The following is a description of a gene set: Genes down-regulated in comparison of regulatory T cell (Treg) from mice infected with S. mansoni versus T effector cells from the infected mice. from publication Layland LE, Mages J, Loddenkemper C, Hoerauf A, Wagner H, Lang R, da Costa CU (PMID 20007528) Although several markers have been associated with the characterization of regulatory T cells (Treg) and their function, no studies have investigated the dynamics of their phenotype during infection. Since the necessity of Treg to control immunopathology has been demonstrated, we used the chronic helminth infection model S. mansoni to address the impact on the Treg gene repertoire. Before gene expression profiling we first chose to study the localization and antigen-specific suppressive nature of classically defined Treg during infection. Presence of Foxp3+ cells were found especially in the periphery of granulomas and isolated CD4+CD25hiFoxp3+ Treg from infected mice blocked IFN-gamma and IL-10 cytokine secretion from infected CD4+CD25- effector T cells (Teff). Furthermore the gene expression patterns of Treg and Teff showed that in total genes were significantly regulated during chronic schistosomiasis. Upon k-means clustering we identified genes exclusively regulated in all four populations including Foxp3, CD103, GITR, OX40 and CTLA-4: classical Treg markers. During infection however, several non-classical genes were up-regulated solely within the Treg population such as Slpi, Gzmb, Mt1, Fabp5, Nfil3, Socs2, Gpr177 and Klrg1. Using RT-PCR we confirmed aspects of the microarray data and in addition showed that the expression profile of Treg from S. mansoni-infected mice is simultaneously unique and comparative with Treg derived from other infections Human Gene Set: GSE17580_TREG_VS_TEFF_S_MANSONI_INF_DN studied in species Homo sapiens, and this is the list of marker genes: ATP2A1, UGGT1, FLI1, SLCO3A1, NEAT1, PPP4R3B, SEMA4A, GPR155 (G protein-coupled receptor 155), SELENOP, EMB, SIDT1, IFIT2, SMARCA2 (SWI/SNF related, matrix associated, actin dependent regulator of chromatin, subfamily a, member 2), S1PR5, RPTN, RPS6KA3, PACC1, CLK4, UPB1, PRXL2C, KLF7, ACTN1, WASHC3, TBX21, PRKD3, PRKX (protein kinase cAMP-dependent X-linked catalytic subunit), OTULINL, MYL11, ITGB5, ADCY6, RPP14, CMPK1, AFP, SLC20A1, SOSTDC1, NRBF2, CTSW, TANC1, ACP5, ATP1B3, KRT81, CLCC1, IGF2BP2, TMEM9B, DMTF1, TMEM71, CACNB3, TCF20, NANOS1, ARL4C, PYCARD, ATP6AP2, DNTT, ANK3, GRAMD1A, CYP2S1, MITD1, MTMR2, LPP, TMT1A, PDLIM4, TNFSF14, MSRA, TIA1, PLEKHO1, STK26, ATXN7L3B, CDC42EP5 (CDC42 effector protein 5), TEC, CARD19 (caspase recruitment domain family member 19), SCG2, DPH6, TAOK1 (TAO kinase 1), CNEP1R1, MBOAT1, TUBB2A, PAWR, RNPC3, UGCG, PPP2R5A, GALNT7, PDK1, RNF166 (NCBI Gene Id 115992), BZW2, DNAJC21, OAS2, GRAP2, GRAMD2B, LMO4, ST8SIA1, ID2, QPCT, TDRP, RIPOR2, UBE2D1, PTRH1, SYNE2, APPL2, ATP1B1, SGMS1, ACVRL1, MSL1, ZBTB20, ADD3, DGCR8, GADD45A, PDLIM1, CD2AP, KCNMB4, ENC1, COX6A2, ING1, CTSA, FXYD2, RMND1, LYST, CBR1, RNF13, FAM3D, S1PR1, RNF32, BCL2, GZMK, SOAT2, ITK, MTURN (maturin, neural progenitor differentiation regulator homolog), PRSS12, HOXD11, LEF1, RSRP1, SYF2 (SYF2 pre-mRNA splicing factor), EVI2B, APPBP2, RFLNB, GGT5, NRAS, PDE7A, CD28, SNX15, SARDH, SFSWAP, TSPYL1, PAQR7 (NCBI Gene Id 255358), ITM2A, KIF1B, GGACT, METTL9, SGK1, SIAH1, NACC2, INPP1, TMLHE, MFSD6, EOMES, MOCS2, PRF1, FBXW7, DENND4C, TTC16, USP38, WIPF1, EHD3, RCHY1, PXMP4, RASGRP1, RANBP10, METTL25B, ARL6IP5, HNRNPA1, RFXAP, IGFBP4 (NCBI Gene Id 3487), SOX4, STK17B, NTRK3, VTA1, RAMP3 (NCBI Gene Id 10268), CCL5, IL2, UBR3, MYLIP, NFE2L2, GPM6B (glycoprotein M6B), ALS2CL, DNAAF11, TVP23A, RAPGEF4, IDH2, TSPAN9, CD84, G0S2, ATE1, RNF145, PDIK1L, SPTSSA, SNHG8, KRAS, PCMTD2, NDUFAF4, DENND2D, UBE2B